Given this list of marker genes EVI2A, HLA-E, ELOVL2, IGLC2, LCP2, PVRIG, CXCL9, EVI2B, CD1C, CROCCP2, IFITM2, RSAD2, CCL4, PTGDS, CPZ, CRYBB2, SEPTIN11, APOBEC3G, GLIPR1, GPR65, IL2RG, HLA-G, SOS1, RGS16, GPM6A, PTPN22, RUNX3, IRF9, COTL1, HLA-B, SECTM1, SYT11, HMGCS2, NR4A3, CEBPD, P2RY14, IL15, IGKV1D-39, ERAP1, IFITM1, IRS2, JCHAIN, PRF1, FBN2, ICAM2 (NCBI Gene Id 3384), IL7R, LAPTM5, PDZRN4, TAP2, HERC6, CD83, SLAMF1, MICAL1, CD37, MMP9, SEPTIN6, TRAT1, MMP19, IGKV3-20, NR4A2, ITGB2, SOX17, ALOX5AP, CREM, CD69, PLCL1, CD48, GBP1, FCGR2B, LYZ, LILRB2, CCL19, RAMP3, CCR7, CLU, ADAMDEC1, HERC5, IGHM, FCER1G, FLI1, GPR18, THEMIS2, LSP1, ETS2, CHRDL1, MS4A1, DUSP2, XAF1 (NCBI Gene Id 54739), HLA-J, FYN, C1QB, HS3ST3A1, STAT1, CTNNB1, OPTN, DNASE1L3, IFI27, ARL4C, ADCY7, SERPINB9, CORO1A, SF1, CMAHP, BTN3A1, PI15, IRF1, UBE2L6, GNG11, GADD45G, NID1, CTSC, IFIT3, RNASE6, CYTIP, IGKC, MX2, ARHGAP25 (Rho GTPase activating protein 25), PLEK (NCBI Gene Id 5341), WNT2B, PTPRC (NCBI Gene Id 5788), CXCR4, SELP, IFI16, DOCK10 (NCBI Gene Id 9714), TMEM35A, PEX14, TCEAL2, MYB, APOL6 (apolipoprotein L6), IGKV1D-37, CCN4, HLA-DRA (NCBI Gene Id 7930), RASA4, PLTP, STK17B, TMX4, TLE4, ADAMTS1, RASGRP1 (NCBI Gene Id 10125), IDO1, SRGN, SOCS1, NFASC, PARP12, FGL2, ARHGAP15 (NCBI Gene Id 55843), GPRC5B, CD93, APOE, CCND1, CCL5, HSPB8, THBD, CD52, ITIH5, ENSG00000291006, ADAM28, ISG20, ZAP70, NPIPB15 (NCBI Gene Id 440348), PLAC8, GSTM3, SERHL, SLA, CLEC4A (C-type lectin domain family 4 member A), MAP4K1, AMFR, PDLIM3, ADRA2C, ANPEP, HLA-DQA1, PECAM1, CSF2RB, GLRX, PSMB8, IGHA1, RASGRP3, C1orf54, ISG15, PPARGC1A, CELF2, TRBC2, CCL8, TCIM, PDK4, CTSS, IGHG1, CCR5, CD53, GZMK, EOGT, IFI44 (NCBI Gene Id 10561), PLEKHO2, LY96, IGLL3P, SELL, CD2, CD86, GPR183, GPR171 (NCBI Gene Id 29909), CD28, SLC7A5, IFNG, SELE, WIPF1, CNN1, FYB1, SCGB1A1, HLA-DRB1, GMFG, IFI44L, POM121L9P, HLA-DPB1, TRBC1, SFTPA2 (surfactant protein A2), HLA-F, COL21A1, IGHV3-21, FCMR, PSPH, LAMP3, DPYSL4, PTPN7, ITGAL, TFEC, TRAC, IL10RA, ECHDC3, NAT1, NFIL3, IGKV1D-13, STOM, CPM, IGLV2-14, ADGRE5, IL16, FBN1, PRIM2, BCL2A1, BCL11B, CDH2, IL1R2, CD3D, DDX60, GIMAP6, STAP1, MYBL1, RAC2, CD207, RNASE1, TMEM158, ADGRG2, IRF8, MRC1, APOL1, VSIG4, HCP5, DNAJC15, RGS1, SYNDIG1, EDNRA, BTN3A2, ITK (NCBI Gene Id 3702), SAMSN1, IFI6, DLC1, PIM2, IFIT1, IGKV1OR1-1, IFITM3, CLIC2, MS4A4A, CLDN5, ADA2, ITGA4, OLFML2A, CDC7, HLA-DQB1 (NCBI Gene Id 7924), NKG7, CD1E, PSMB9, C5AR1, LCK, GZMA, OAS2, NCKAP1L, NLRP1, JCAD, TYMP, MX1, PDHA1, HCLS1 (hematopoietic cell-specific Lyn substrate 1), POU2AF1, MCUB, UCP2, APOLD1, SLFN12, MXRA7, AHNAK2, TAP1, CD8A, CD27, C1QA, here is a description of the gene set: from publication Wallace TA, Prueitt RL, Yi M, Howe TM, Gillespie JW, Yfantis HG, Stephens RM, Caporaso NE, Loffredo CA, Ambs S (PMID 18245496) The incidence and mortality rates of prostate cancer are significantly higher in African-American men when compared with European-American men. We tested the hypothesis that differences in tumor biology contribute to this survival health disparity. Using microarray technology, we obtained gene expression profiles of primary prostate tumors resected from 33 African-American and 36 European-American patients. These tumors were matched on clinical variables. We also evaluated 18 nontumor prostate tissues from seven African-American and 11 European-American patients. The resulting datasets were analyzed for expression differences on the gene and pathway level comparing African-American with European-American patients. Our analysis revealed a significant number of genes, e.g., 162 transcripts at a false-discovery rate of <or=5% to be differently expressed between African-American and European-American patients. Using a disease association analysis, we identified a common relationship of these transcripts with autoimmunity and inflammation. These findings were corroborated on the pathway level with numerous differently expressed genes clustering in immune response, stress response, cytokine signaling, and chemotaxis pathways. Several known metastasis-promoting genes, including autocrine mobility factor receptor, chemokine (C-X-C motif) receptor 4, and matrix metalloproteinase 9, were more highly expressed in tumors from African-Americans than European-Americans. Furthermore, a two-gene tumor signature that accurately differentiated between African-American and European-American patients was identified. This finding was confirmed in a blinded analysis of a second sample set. In conclusion, the gene expression profiles of prostate tumors indicate prominent differences in tumor immunobiology between African-American and European-American men. The profiles portray the existence of a distinct tumor microenvironment in these two patient groups. Genes up-regulated in prostate cancer samples from African-American patients compared to those from the European-American patients. studied in species Homo sapiens Human Gene Set: WALLACE_PROSTATE_CANCER_RACE_UP